Given this list of marker genes Tmem130, Col8a2, Hoxb7, Dnal1, Gpr55, Pim2, Creb5, Kcna2, Slc26a3, Zfp365, Arf6 (ADP-ribosylation factor 6), Tnfsf15, Gda, Trim5, Rnf144a, Dbt, Slc17a8, Atg13, Sdc3 (syndecan 3), Oxct1, Foxo4, Ino80d, Pcyt1b (phosphate cytidylyltransferase 1, choline, beta isoform), Pgm2l1, Loxl2, Fam53c, Kif5a, H2-M2, Katnal1, Ptprn2, Adgrf5, Rgs6, Colec11, Clrn1, Nol3, Hs3st4, Eea1, Scfd2, Faf2, Zfp318, Lpl, Chd7, Zfp704, Lat2, Atf7ip, here is a description of the gene set: from publication Chen Y, Wang X (PMID 31504780) Genes predicted to be targets of miRBase v22 microRNA mmu_miR_7685_5p in miRDB v6.0 with MirTarget v4 prediction scores > 80 (high confidence targets). studied in species Mus musculus Mouse Gene Set: MIR_7685_5P